Given this list of marker genes LYPD6B, VNN1, CEACAM7, PIGZ, PGAP1, DPM2, LYPD5, PLET1, CD109, OTOA, SPACA4 (NCBI Gene Id 171169), PIGB, LY6D, FCGR3B, DPM3, ALPG, PIGQ, PIGS, PIGX, LYPD1, PIGV, XPNPEP2, LY6G6D, CD52, SPRN, CEACAM5, VNN2, PIGP (phosphatidylinositol glycan anchor biosynthesis class P), CNTN4, PIGL, TECTA, MELTF, FOLR2 (NCBI Gene Id 2350), PIGN, OPCML, MDGA1, PIGK (NCBI Gene Id 10026), ULBP2, GPAA1, PIGH, LY6G6C, PIGT, PIGY, NTNG1, NTNG2, TEX101, NRN1, BST1, PIGU, LY6H (lymphocyte antigen 6 family member H), LYPD3, PIGC, LYPD4, RAET1L, MSLN, LY6K, LY6E, LYPD2, PIGO, CPM, LSAMP, GP2, CNTN3, ART4, TECTB, NEGR1, NRN1L, PRSS41, GPIHBP1, MDGA2, PIGM (phosphatidylinositol glycan anchor biosynthesis class M), RECK, PIGW, RTN4RL1, LYPD8, CNTN5, PRND (prion like protein doppel), RAET1G (NCBI Gene Id 353091), PIGG, ALPI, PLAUR, PIGA, ART3 (NCBI Gene Id 419), IZUMO1R, THY1, PIGF, NTM, GPLD1, DPM1, PSCA, PRSS21, ALPL, RTN4RL2, here is a description of the gene set: species: Homo sapiens Glycosylphosphatidyl inositol (GPI) acts as a membrane anchor for many cell surface proteins. GPI is synthesized in the endoplasmic reticulum. In humans, a single pathway consisting of eleven reactions appears to be responsible for the synthesis of the major GPI species involved in membrane protein anchoring.<p>As a nascent protein fated to become GPI-anchored moves into the lumen of the endoplasmic reticulum, it is attacked by a transamidase complex that cleaves it near its carboxy terminus and attaches an acylated GPI moiety. The GPI moiety is deacylated, yielding a protein-GPI conjugate that can be efficiently transported to the Golgi apparatus. Reactome Pathway: Post-translational modification: synthesis of GPI-anchored proteins part of: Post-translational protein modification